The following is a description of a gene set: IFN-gamma transcriptional responses in control and IFN-gamma primed primary human macrophages Genes down-regulated in macrophages stimulated by IFNG for 24h: control versus primed by IFNG. studied in species Homo sapiens Human Gene Set: GSE1925_CTRL_VS_IFNG_PRIMED_MACROPHAGE_24H_IFNG_STIM_DN from publication Hu X, Park-Min KH, Ho HH, Ivashkiv LB (PMID 16148108), and this is the list of marker genes: GEMIN5, COX17, PNP, EIF2AK3 (eukaryotic translation initiation factor 2 alpha kinase 3), COX7A2L, PCBP2, EPB41L4A-AS1, PGM1, ANXA2, ANKIB1, NF2, TPPP3, GAR1 (NCBI Gene Id 54433), KRT13 (NCBI Gene Id 3860), GCLM, MRPL16, SPG21 (NCBI Gene Id 51324), IL2RA, PMF1, TRAF3, IRF1, IL18R1, CRAMP1, ISG15, GAS2, SLCO5A1 (NCBI Gene Id 81796), MTDH, PDLIM1, ICAM1, SRP9, CHMP4B, WNT5A, PPOX, ITGA4, AK2, IRF9, DUSP12, ISG20, CHADL, TMEM70, GBX2, SOWAHA, CDC25C, ENSG00000286190, HLA-G (NCBI Gene Id 3135), RHOQ, MCEE, IPO7, NDST1, SPA17, GBP2, APOE, ZNF436, DNAJC15, PCSK1, ENDOU, CDK11B, CSN2, CNN3, CASC3, GLA, FRRS1, NUDT19, LDLR, SNX10, COQ3, CCND2, SELL, NOP10, HGSNAT, SNHG6, ACADL, GNB5, AGTRAP, GBP4, MFHAS1, IGF2R, ILF3, BLK, WRN (NCBI Gene Id 7486), IFRD2, PDK1, ANG, POM121, WARS1, WT1, AKAP9, HDGF, ATP6V1D, DAD1, PEX7, ERO1B, PARP8, TMEM150A, CYB5A, NAB2, SLC25A47, UBR7, MTHFD2, RMND1, HS3ST1, LY6E, IDH3B, DBI, HTR3A, SPAG5, IFIT3, ZNF398, EMD, SUCLG2, NOC4L (nucleolar complex associated 4 homolog), GCOM1, KIT (NCBI Gene Id 5086), IRGM, MCUR1, POU6F1, S100A16, GTPBP4, PPIA, HAT1, USP18, SOD1, RPL10, S100A6, ADAR, ISL1 (ISL LIM homeobox 1), HPCAL1, SC5D, MTIF2, SLC1A5, TPD52, ATP5F1A, PRPS2, MAP7, PLAC8, GZMA, RSAD2, RNASE4, AURKA, DIAPH3, PLK1, SHISA5, NUP107, FAM167B, RCN1, METTL8, CRNKL1, TRIM21, PLA2G12A, CDT1, IFIH1, EPAS1, B2M (beta-2-microglobulin), ARHGEF3, PSME2, CADPS, IFITM3, SERPINB9, IFIT1B, IVD, MAP2K4, APEX1, USP39 (NCBI Gene Id 10713), NHERF1, TMEM14C, IFI27, HDAC1, KIF23, MX2, PIK3CD, LGALS3BP, RECQL, RCC2, DPAGT1, NFKB1, QSOX1, JAGN1, MFF (mitochondrial fission factor), SLC11A2, NTMT1, UMPS, HNRNPDL, EFNA2, GGH, RBM8A, TNFSF10, RAE1, CWC22, ZYG11B, S100A11, CD8B, NFATC1, DOCK2, ACTR1A, CKB, DENND2B, CCDC152, NUMA1, PPRC1, ACTB